The following is a description of a gene set: Mouse Gene Set: GOBP_PHOSPHOLIPID_TRANSPORT species: Mus musculus The directed movement of phospholipids into, out of or within a cell, or between cells, by means of some agent such as a transporter or pore. Phospholipids are any lipids containing phosphoric acid as a mono- or diester., and this is the list of marker genes: Abca1, Tmem30b, Slc4a1, Atp8b4, Kcnn4, Xkr7, Clptm1l, Pla2g10, Osbpl5, Abcb4, Pitpna, Abca4, Apoa1, Apoc2l, P2rx7, Plscr5, Atp11a, Mttp, Tmem41b, Atp10b, Plscr1l1 (NCBI Gene Id 78459), Tmem30a, Ano7, Atp8b2, Atp11c, Apoa2, Abcb1b, Osbpl2, Apoc3, Prap1 (NCBI Gene Id 22264), Atp9b, Abca7, Apoc2, Xkr6, Apoe, Scarb2, Vapa, Xkr4, Serinc5, Pitpnm3, Serinc3, Atp8a1, Tnfaip8l3, Etnppl, Spns1, Dbi, Scarb1, Atp10d, Fasl, Xkr9, Trpc5, Abcb1a, Cptp, Vdac2, Mfsd2a, Plscr4 (NCBI Gene Id 235527), Atg9a, Ano4, Apoc1, Atp11b, Pitpnm1, Atp8b1, Osbp (NCBI Gene Id 76303), Bltp1, Xrcc4, Apoa4 (apolipoprotein A-IV), Abca12, C2cd2l, Triap1, Prelid1, Pitpnm2, Prelid3b, Tmem30c, Abcg1, Pltp, Apoa5, Prelid3a, Plscr3, Plscr1, Atp8b3, Abcg8, Esyt1, Osbpl8, Scp2, Abcc1, Atp9a, Ldlr, Pitpnb, Ano9, Pctp, Atp10a, Atg9b, Xkr8, Serinc2, Slc66a2, Vmp1, Abca3, Prelid2, Pitpnc1, Atp8b5, Ano3, Ano6, Atp8a2, Plscr2